The following is a description of a gene set: Any process that increases the rate, frequency or extent of myofibril assembly by organization of muscle actomyosin into sarcomeres. The sarcomere is the repeating unit of a myofibril in a muscle cell, composed of an array of overlapping thick and thin filaments between two adjacent Z discs. studied in species Mus musculus Mouse Gene Set: GOBP_POSITIVE_REGULATION_OF_SARCOMERE_ORGANIZATION, and this is the list of marker genes: Prox1, Bmp10, Ep300, Edn1, Prkd1, Mylk3